The following is a description of a gene set: Genes up-regulated in day 7 memory B cells versus day 7 germinal center B cells. from publication Kaji T, Ishige A, Hikida M, Taka J, Hijikata A, Kubo M, Nagashima T, Takahashi Y, Kurosaki T, Okada M, Ohara O, Rajewsky K, Takemori T (PMID 23027924) Human Gene Set: GSE11961_MEMORY_BCELL_DAY7_VS_GERMINAL_CENTER_BCELL_DAY7_UP To obtain insight into the genetic basis of the increase of functional activity of memory B cells over time, we compared the gene expression profiles of day 7 and day 40 NP-specific/IgG1 memory B cells, GC B cells and plasma cells in immunized WT mice and naïve B cells, before and after activation in vitro. species: Homo sapiens, and this is the list of marker genes: SLCO3A1, S100A6 (S100 calcium binding protein A6), ARL2BP, ABI2, TXNDC9, GPR65, GIMAP4, RBFOX3, WBP1L, EML3, SNX10, ORAI1, ID2, GALNT2, SOS2, NRBF2, STMP1, PDE3B, ADGRG3, DRAM1, NAPEPLD, MMD, SLC20A1, POT1, DNAJC15, LONRF3, TMPRSS3, COX19, SNORD89, DYRK2, CDK2AP1, PLD1, HOPX, IKBIP, AGO2, GTF3C3, SCOC, TM9SF4 (NCBI Gene Id 9777), CAMK1, CNOT6L, ELOVL1, CYP17A1, SNAP91, HROB, ARRDC4, UBAP1, COX10, UGCG, HTRA1, CD2, AIRN, RUNDC3B, CLDN16, MYOM2, IKZF4, CHST13, RBL2, HLA-A, KLHDC2 (NCBI Gene Id 23588), OCIAD2, SLC2A10, S100A1 (S100 calcium binding protein A1), CISH, GLIPR1, MTA3, RNPEP, BMPR2, ATP9B, EXOC5, SPARC, AJUBA, PAM, RTL8C, GAREM1, C15orf40, TMEM71, MAP7D1, RPGR, RAP2B, TIMP2, SRD5A3, BICDL1, PTPRE, PADI4, GLRA1 (glycine receptor alpha 1), MED28 (NCBI Gene Id 80306), VPS26B, NRIP1, NUCB1, YIPF5, PARD6G, NLRC5, ITGB2, TMBIM1, RAB32, GAB3, DMRTA1, GYG1, RASGEF1A, GPR68, DSP, TJP1, ARHGAP9, POLK, RHOC, MTFR1L, OR11H4, VSIR, ADD1, ERN1, ATP11A, RNF182, ZC2HC1A, SELENOP, FUCA2, INPP1, LEPROTL1, DENND2B, RNASEL, MED30, ANXA1, RXRA (retinoid X receptor alpha), FBLN7, FRMD4A, YAF2, SIDT1, ARHGAP21, RAI1, ELK3 (ETS transcription factor ELK3), ORMDL1, PLS3, TGFBRAP1, KIT, CTNNA1, CCDC102A, PDE1C, MEMO1, NEUROG2, SPACA9, KLHL25, VPS26C, DNAJC1, ANKRD50, ITGAE (integrin subunit alpha E), ELMO2, BSN, PRF1, TSHZ3, MBD5, CPEB2, GGH (gamma-glutamyl hydrolase), ZDHHC15, PLEC, ADIPOR2, ICA1, C8B, JAK1, RPS6KA1, IFIT2, AHNAK, ICA1L, DNER, COPS5, FAM184A, PRPSAP1, FNIP2, SLC35B4, CALCRL, STN1, COL4A3, MINDY3, MPZL2, NR5A1, COPZ2, STX11, EMP3, RER1, ANKRD24, TNFRSF25, VIM, ERAP1, ZFP36L2, UBASH3A, ITK, SH3RF1, MAGOHB (NCBI Gene Id 55110), ANKRD44, GOSR1, KCNQ3, NUP50, RASL11B, RAP1B, DHRS3, SLC39A8, DPPA2, CELA1, GSR, CAPSL, CRYBG1, ABHD14A (NCBI Gene Id 25864)